The following is a description of a gene set: part of: Metabolism of amino acids and derivatives Reactome Pathway: Phenylalanine and tyrosine metabolism The hydroxylation of phenylalanine, an essential amino acid, to form tyrosine is a major source of the latter amino acid in the body under normal conditions and is also the first step in phenylalanine catabolism. To continue the catabolic process, tyrosine is transaminated to 3-(4-hydroxyphenyl)pyruvate which is broken down to fumarate and acetoacetate. studied in species Homo sapiens, and this is the list of marker genes: QDPR, PAH, FAH, ASRGL1, TAT, HGD, GSTZ1, PCBD1, IL4I1, HPD, KYAT1